The following is a description of a gene set: Human Gene Set: GOBP_REGULATION_OF_INSULIN_RECEPTOR_SIGNALING_PATHWAY species: Homo sapiens Any process that modulates the frequency, rate or extent of insulin receptor signaling., and this is the list of marker genes: FFAR3, KANK1, SORBS1, SIRT1, PRKCQ, GRB14, MSTN (myostatin), SORL1, IL1B (interleukin 1 beta), PTPRJ, AHSG, GKAP1, RPS6KB2 (NCBI Gene Id 9017), PRKCD, GSK3A, LONP1, SOCS1, PRKCB, ERFE, OGT, MZB1, BLVRB, GRB7, NCK1, PAK1 (p21 (RAC1) activated kinase 1), PRKCZ, IRS1, SERPINA12, ZNF592, SOCS3, NCL, FBXW8 (NCBI Gene Id 26259), PTPN11, MIR1271, TRIB3, MIR103A1, MAPKAP1, RBX1, SNX5, CUL7, TRIM72, ADIPOR1, PTPN1, MTOR, NUCKS1, PTPN2, PIP4K2B, SLC27A4, TSC2, LEP, NR1H4, CTSD, PID1, GRB10, INPP5K, GPR21, PTPRE, MIR15B, SIK2, VWA2, SESN3, PIP4K2C, PIP4K2A, C1QTNF12, TNS2, INS, IGF2, ZBTB7B, OSBPL8, ENPP1 (NCBI Gene Id 5167), MIR107, PRKAA1, NCOA5, RELA, RBM4, RPS6KB1 (ribosomal protein S6 kinase B1), FUT7, MIR195